The following is a description of a gene set: species: Homo sapiens The change in morphology and behavior of a neutrophil resulting from exposure to a cytokine, chemokine, cellular ligand, or soluble factor, leading to the initiation or perpetuation of an immune response. Human Gene Set: GOBP_NEUTROPHIL_ACTIVATION_INVOLVED_IN_IMMUNE_RESPONSE, and this is the list of marker genes: VAMP2, VAMP7, DNASE1L3, CD177, FCER1G, STXBP3, LILRA2, PRAM1, GKN2, SYK, ITGAM, TYROBP, STXBP2, SCNN1B, VAMP8, ANXA3, BCR, DNASE1, ITGB2, SPI1, MYD88